The following is a description of a gene set: from publication Darce J, Rudra D, Li L, Nishio J, Cipolletta D, Rudensky AY, Mathis D, Benoist C (PMID 22579475) Genes up-regulated in Foxp3-ires-GFP T reg (FOXP3+): B6 versus NOD background. studied in species Homo sapiens The aim of this study was to quantify the impact of chimeric Foxp3-GFP protein on the Treg cell transcriptional program. Human Gene Set: GSE37605_C57BL6_VS_NOD_FOXP3_IRES_GFP_TREG_UP, and this is the list of marker genes: ENKUR, GJD3, CPNE4, ABCB11, SNORD14E, ZFP41, CHRNA4, MAP3K7CL, EEF1G, GCK, LBX1, EPHB6, COA4, HYDIN, TAF7L, AIPL1, CITED1, IRX2, MALL, KRT18, SSC5D, TMEM212, RIMS2, MLXIPL, TTC24, CNTNAP4, METTL23, MYH15, DOLK, CCDC117 (NCBI Gene Id 150275), NPPA, MYH7, LRRC3B (NCBI Gene Id 116135), EPHA6, FXYD2, OCLN, FBP2, CDHR2, SASH3, MAFA, NGB, GRID2IP (NCBI Gene Id 642177), CLDN25, RIMBP2, SNX29, THSD4, CHML, MAPK13, SCN2B (NCBI Gene Id 6327), PIWIL4, SLC22A20P, CCDC190, ANKRD33B, MESP2, HSPA4, SLC6A16, HOXA13, CACNA1A, FAM221B (NCBI Gene Id 392307), GALR1, SNPH, MIR191, CHRNA10, PROC, VPREB1, SLURP1, SHISAL2B, GULOP, POU3F2, PANX2, CIMIP7, ABCC2, MAPK12, ISL2 (ISL LIM homeobox 2), MIR346, NPAS2, HNRNPH3, LRMDA, CREBL2, PSORS1C2, PROCA1, C8A, MBD3L1, HRH4, MIR615, PDZPH1P, CNR2, SETBP1, SYNGR4, CTU1, CDH18, TMEM207, FMR1NB, FZD6, FAM83C (family with sequence similarity 83 member C), VGLL1 (vestigial like family member 1), ASGR2, CHRM1, C20orf173, FERMT1, C4orf17, KCNV1, NEDD9 (neural precursor cell expressed, developmentally down-regulated 9), ADAM12, EEF1A2, GPR101, PDCD2, MS4A12, DPH3P1 (NCBI Gene Id 140827), SLCO4A1, KRTAP7-1, CXorf49, EXOC8, SETD4, TACR3, CMAHP, MRGPRD, TMEM121, SLC24A1, OLIG1, IGSF11, TNFAIP8L2, KLHL34, TDO2, SEBOX, NPFFR1, H2AB1, IL17F, MIR138-1, PWWP2A, PKP1